The following is a description of a gene set: Cytoplasmic DNA triggers the activation of the innate immune system. While downstream signaling components have been characterized, the DNA sensing components remain largely elusive. We performed a systematic proteomics screen for proteins that associate with DNA, traversed to a screen for IFN-β-induced transcripts. We identified DSIRE (DNA sensor for the IL-1β response, previously called AIM2) as a candidate cytoplasmic sensor. DSIRE showed a marked selectivity for double-stranded DNA. DSIRE can recruit the inflammasome adaptor ASC and gets redistributed to ASC speckles upon coexpression of ASC. RNAi-mediated reduction of DSIRE expression led to an impairment in IL-1β maturation. Reconstitution of unresponsive cells with DSIRE, ASC, caspase 1 and IL-1β showed that DSIRE is sufficient for inflammasome activation. Overall, our data strongly suggest that DSIRE is a cytoplasmic DNA sensor for the inflammasome. from publication Bürckstümmer T, Baumann C, Blüml S, Dixit E, Dürnberger G, Jahn H, Planyavsky M, Bilban M, Colinge J, Bennett KL, Superti-Furga G (PMID 19158679) Genes down-regulated in L929 cells (fibroblast): control versus stimulated with IFN-b. studied in species Homo sapiens Human Gene Set: GSE14413_UNSTIM_VS_IFNB_STIM_L929_CELLS_DN, and this is the list of marker genes: SIAE, ATP6V1C2, ASIC2, SLC39A9, SLC7A9, RSPO3, CNTN3, SLC39A3, FAM32A, MIR211, OR1D2, CER1, PDGFRB, ST18, DEFB130A, RNF34 (NCBI Gene Id 96268), MRAP2, CES4A (NCBI Gene Id 283848), VPS26C, RAB3IP, FCAMR, TTLL8, SLC12A5, DYNLL1, PJA1, IGFLR1, HSF2BP (NCBI Gene Id 11077), RNF112, CYB561D2, AFAP1 (NCBI Gene Id 60312), SLC38A5, MED4, ABCG5, KCNH5, ATOH8, WDR5B, UGGT1, MSRB2 (NCBI Gene Id 51648), GNG4, AQP1, VSTM2A, CYTH4, NPHP4, BAIAP3, DNMT3B, EML1, GPR75, ALPG, BTN1A1, GSX1, SPACA1, NPY2R, CHMP3, XCR1, ITGA2, PPIL2, CETN1, FAT3, STX8, CADM2, TRPM1, RFT1, C18orf32, KCNT2, RFX4, GABRG3, PMFBP1, MYLK4, SEC16B, DLK2, TGM4, OFCC1, MAGEF1, TTYH1, CSF3R, S100A16, PLB1, KIRREL3, GPR151 (G protein-coupled receptor 151), ANKRD10, CYP7B1, OGFOD1, QTRT1, TRIM40, RFK, HOXA7, APLN, HDGFL1, MIR183, PDE10A, PLPP7, OLIG3, CSRP3, MIPEP, NGB, WFDC3, HMG20A, TPO, HSD3B2, DKK4, SPATA20, DDX24, ADAMTS20, LDOC1, LYPLAL1, MRPL9 (mitochondrial ribosomal protein L9), CCR10, JAKMIP2, SGCZ, HTR5BP, ANPEP, FAM163B, EDC3, LCMT2, NIPAL1, TAFAZZIN, IQCE, SLC14A1